The following is a description of a gene set: Swollen lip Human Gene Set: HP_SWOLLEN_LIP Enlargement of the lip typically due to fluid buildup or inflammation. species: Homo sapiens, and this is the list of marker genes: PHGDH, MYOF, PLG, XPNPEP2, ANGPT1, KNG1, HS3ST6